Given this list of marker genes PIAS1, UBE2N, CDK7, DDB2, RAD23A, RAD23B, UBB, SUMO2, GTF2H1, UBA52, SUMO3, ERCC2, RPA1, GTF2H3, RPS27A, UBE2V2 (ubiquitin conjugating enzyme E2 V2), XPC, RNF111, DDB1, GTF2H2, SUMO1, RPA2, ERCC1, RPA3, UBE2I, XPA, PARP1, CUL4B (NCBI Gene Id 8450), RBX1, USP45, ERCC4, PARP2, CCNH, CHD1L, GTF2H5 (NCBI Gene Id 404672), ERCC3, CETN2, GTF2H4, ERCC5, CUL4A, MNAT1, UBC, PIAS3, here is a description of the gene set: part of: Global Genome Nucleotide Excision Repair (GG-NER) Reactome Pathway: Formation of Incision Complex in GG-NER After the XPC complex and the UV-DDB complex bind damaged DNA, a basal transcription factor TFIIH is recruited to the nucleotide excision repair (NER) site. DNA helicases ERCC2 (XPD) and ERCC3 (XPB) are subunits of the TFIIH complex. ERCC2 unwinds the DNA around the damage in concert with the ATPase activity of ERCC3, creating an open bubble. Simultaneously, the presence of the damage is verified by XPA. The recruitment of XPA is partially regulated by PARP1 and/or PARP2.<p>Two DNA endonucleases, ERCC5 (XPG) and the complex of ERCC1 and ERCC4 (XPF), are recruited to the open bubble structure to form the incision complex that will excise the damaged oligonucleotide from the affected DNA strand. The RPA heterotrimer coats the undamaged DNA strand, thus protecting it from the endonucleolytic attack (De Laat et al. 1998). species: Homo sapiens